Given this list of marker genes NXPH3, NRIP2, IL1RAP, ROPN1, REEP2, SH3KBP1, HIC2, UNC5B, GTPBP1, GSG1L, FGA, PPARGC1B, ZMIZ1, CEP85L, TAB2, FBRS, UCK2 (NCBI Gene Id 7371), PALLD, RAB5IF, KCNE1, ZFR2, NXF2, HIVEP3, FMNL3, RIMS2, SYDE2, MYORG, CACNA1E, MGAT5B, SESTD1, HSBP1L1, TGIF2-RAB5IF, NFIC, UBE2V1, COBL, AKAP13, ZNF445, SORCS2, FLT4 (fms related receptor tyrosine kinase 4), PURA, GRAMD2A, LRP2BP, PDZRN3, PRELP, PHF8, NMUR1, KRTAP5-6, SH3TC2, SGK2, ERC1, TTYH3, CALN1, ANKIB1, CXXC4, MED13L, ROBO2, DTNBP1, NSG1, SLC16A2, VSX2, ASCC1, TMEM217, ASTE1, PATZ1, EI24, CCDC57, MCCC2, DLK1, SNX19, ZYX, IQSEC2, KCNJ10, THG1L, GCNT4, KCNH4, FBXO41, GPR55, ALOXE3, COL23A1 (collagen type XXIII alpha 1 chain), NXF2B, SMURF1, ADARB2, PCBP2, RTL9, ARMC8, RAB7A, MAPK6, KCNAB2, CHRNB4, VAMP1, ALPI, PPP3R1, FOXJ2 (NCBI Gene Id 55810), ZMYND8, RGS6, SHISAL1, SLC25A34, FUT5, here is a description of the gene set: Human Gene Set: MIR4483 Genes predicted to be targets of miRBase v22 microRNA hsa-miR-4483 in miRDB v6.0 with MirTarget v4 prediction scores > 80 (high confidence targets). from publication Chen Y, Wang X (PMID 31504780) species: Homo sapiens